Given this list of marker genes Hgf, here is a description of the gene set: species: Mus musculus electronically inferred by orthology from the curated human pathway This event has been computationally inferred from an event that has been demonstrated in another species.<p>The inference is based on the homology mapping from PANTHER. Briefly, reactions for which all involved PhysicalEntities (in input, output and catalyst) have a mapped orthologue/paralogue (for complexes at least 75% of components must have a mapping) are inferred to the other species. Reactome Pathway: Drug-mediated inhibition of MET activation part of: Negative regulation of MET activity